Given this list of marker genes Abl1, Dact1, Cdh24, Ptprt, Ccdc85b, Ctnnb1, Ptprj, Dact3, Cdh26, Plekha7, Dact2, here is a description of the gene set: Mouse Gene Set: GOMF_DELTA_CATENIN_BINDING Binding to the delta subunit of the catenin complex. species: Mus musculus